The following is a description of a gene set: Any process that modulates the frequency, rate or extent of signaling via the CD40 signaling pathway. Mouse Gene Set: GOBP_REGULATION_OF_CD40_SIGNALING_PATHWAY studied in species Mus musculus, and this is the list of marker genes: Sharpin, Tnfsf18, Fanca, Trem2, Slamf1 (signaling lymphocytic activation molecule family member 1), Fancd2, Tnfaip3